The following is a description of a gene set: Human Gene Set: MIR4708_3P Genes predicted to be targets of miRBase v22 microRNA hsa-miR-4708-3p in miRDB v6.0 with MirTarget v4 prediction scores > 80 (high confidence targets). from publication Chen Y, Wang X (PMID 31504780) species: Homo sapiens, and this is the list of marker genes: CPEB1, UXS1 (UDP-glucuronate decarboxylase 1), SPCS3, DUOXA1, ADGRL2, NTM, KDM2B, SPOCK3, ITGB5, ZNF704, DAAM1, CSNK1A1, MATR3, CNOT9, SERP1, TMEM245, LINGO2, FMR1, SYNCRIP, RRAGC, DNMT3A, TEX261, CSNK1A1L, LRCH1, STK24, CPN2, GPD1L, SPTSSB, PEX5L, KIF26B (kinesin family member 26B), SPRR1B, ZXDA, FAM181A, PTBP2, AXDND1, RAPH1, HNRNPLL, FRAS1, PAK1, REEP2, CACNB4, PRDM10, NOTCH3, UEVLD, NEMF, VAT1, RIPOR2, UBE2O, RPGR, EFNB2, NUP210, TMC1, LUC7L3, USP38, CETN2, PUS7, SLIT1, ST7L, SLC9A6, FGF14, FRMD4B, FN3KRP, PRKD1, AGO4, CHIC2, SH3PXD2A, OPA1, DSEL (dermatan sulfate epimerase like), XKR8, CNIH4, PIANP, GRB2, ZNF275, LGALS8, BAZ2B, SIDT2, OSMR, ZNF521, CNKSR3, CALU, KRBOX5, TP53INP1, CEP43, JPH3, KCNK10, CDH20, PALM2AKAP2, PUM2, NECAP1 (NCBI Gene Id 25977), CCDC6, GCNT3, SLC25A13, NFIA, NUFIP2, GALNT10, KLF7, PCDH8, CTNNB1, ZSCAN12, SEMA7A, RALGAPB, IL18BP, REEP4